The following is a description of a gene set: Genes predicted to be targets of miRBase v22 microRNA hsa-miR-4468 in miRDB v6.0 with MirTarget v4 prediction scores > 80 (high confidence targets). from publication Chen Y, Wang X (PMID 31504780) Human Gene Set: MIR4468 studied in species Homo sapiens, and this is the list of marker genes: PITPNM3 (PITPNM family member 3), ATXN1, PTPRT, GNAI3, SERTAD2, PELI1, KRBOX5, LATS2, PAX3, BDKRB2, IGF1R, JAK2, PPP3R1, TEX261, PPTC7, CLOCK, BMF, BACH2 (BTB domain and CNC homolog 2), VSX2, GARIN6 (NCBI Gene Id 196472), TNFAIP1 (NCBI Gene Id 7126), EFS, DPPA5, ZNF730, RBPJ (recombination signal binding protein for immunoglobulin kappa J region), MTUS1, GAP43, CADM1, DCLK1, JRKL, WDFY1, KRTAP9-2, MS4A15, HIPK2, ARHGEF37, ADCY9, PLXNA2, MRPS30, BEND2, PPP4R3A, ADAM22, SERPINB2, DIPK1A, BBOX1, KIF11, PTPRR, HLA-DPB1, ADH1C (NCBI Gene Id 126), DTWD1, TEF, ALDH6A1, ACADL, ATAD2B, KRT39, PGAP1, KIF21A, PHKG2, ALCAM, USP10, TPRG1, SGCZ, FKBP5, AKIRIN1, SYT14, RASSF2, TTPAL, CEACAM4, EPHA2, TNRC6B, SLC35A5, FBXL20, MAPK8IP3, QPRT, ZNF571, ADH1A, SEMA6A, BSN, GPR174, UTY, SF3B1, CDC42SE2, PLOD2, NARS1, ADPRM (ADP-ribose/CDP-alcohol diphosphatase, manganese dependent), TSPAN5, CDK19, KRTAP9-8, JMJD6, ZC4H2, REG4, RGS7BP, TMEM230, CLSTN2, DHX36, CRYBA1, OSER1, WNT9B, LPCAT2, GABBR1, PDE12, RC3H1, CAMSAP1, PPM1L, LRP8, CYB561D1, STX11, ATG14 (autophagy related 14), KAT7, LDLRAD3, SDCCAG8 (SHH signaling and ciliogenesis regulator SDCCAG8), DNAJC3, FKBP1B, CCDC144NL, KANK4, BSDC1, TPM3, CRIM1, RIMS3, KDM2A